The following is a description of a gene set: species: Homo sapiens The directed movement of dopamine into, out of or within a cell, or between cells, by means of some agent such as a transporter or pore. Dopamine is a catecholamine neurotransmitter and a metabolic precursor of noradrenaline and adrenaline. Human Gene Set: GOBP_DOPAMINE_TRANSPORT, and this is the list of marker genes: SNCA, GDNF, CHRNA4, DRD4, OPRK1, SLC22A3, MAPK15, SYT11, SLC29A3, FGF20, GABBR1, CXCL12, SYT4, NPY2R, SLC29A4, SLC6A3, SLC22A1, KPNA4, SYT1, COMT, DRD3, SLC18A2, CHRNA6, PINK1, CHRM5 (NCBI Gene Id 1133), SLC18A1, DRD2 (dopamine receptor D2), GNAT1, TGM2, SLC22A2, HTR2A, DRD1, SNCG, GRM2, CHRNB2, RAB3B, SLC6A2, PRKN, KCNA2, TOR1A, PARK7, DTNBP1, ABAT